The following is a description of a gene set: studied in species Mus musculus Mouse Gene Set: GOMF_TAU_PROTEIN_BINDING Binding to tau protein. tau is a microtubule-associated protein, implicated in Alzheimer's disease, Down Syndrome and ALS., and this is the list of marker genes: Dyrk1a, Hspa2, S100b, Apbb1, Hsp90ab1, Gsk3b, Ppp2r2a, Snca, Ppp2ca, Fyn, Bag2, Apoe, Smad2, Bin1, Aatf, Mark2, Hsp90aa1, Sgk1, Hdac6 (NCBI Gene Id 20374), Picalm, Clu, Fkbp4, Ttbk1